The following is a description of a gene set: from publication Tien MT, Girardin SE, Regnault B, Le Bourhis L, Dillies MA, Coppée JY, Bourdet-Sicard R, Sansonetti PJ, Pédron T (PMID 16394013) species: Homo sapiens Human Gene Set: TIEN_INTESTINE_PROBIOTICS_6HR_UP Genes up-regulated in Caco-2 cells (intestinal epithelium) after coculture with the probiotic bacteria L. casei for 6h. Shigella invades the human intestinal mucosa, thus causing bacillary dysentery, an acute recto-colitis responsible for lethal complications, mostly in infants and toddlers. Conversely, commensal bacteria live in a mutualistic relationship with the intestinal mucosa that is characterized by homeostatic control of innate responses, thereby contributing to tolerance to the flora. Cross-talk established between commensals and the intestinal epithelium mediate this active process, the mechanisms of which remain largely uncharacterized. Probiotics such as Lactobacillus casei belong to a subclass of these commensals that modulate mucosal innate responses and possibly display anti-inflammatory properties. We analyzed whether L. casei could attenuate the pro-inflammatory signaling induced by Shigella flexneri after invasion of the epithelial lining. Cultured epithelial cells were infected with L. casei, followed by a challenge with S. flexneri. Using macroarray DNA chips, we observed that L. casei down-regulated the transcription of a number of genes encoding pro-inflammatory effectors such as cytokines and chemokines and adherence molecules induced by invasive S. flexneri. This resulted in an anti-inflammatory effect that appeared mediated by the inhibition of the NF-kappaB pathway, particularly through stabilization of I-kappaBalpha. In a time-course experiment using GeneChip hybridization analysis, the expression of many genes involved in ubiquitination and proteasome processes were modulated during L. casei treatment. Thus, L. casei has developed a sophisticated means to maintain intestinal homeostasis through a process that involves manipulation of the ubiquitin/proteasome pathway upstream of I-kappaBalpha., and this is the list of marker genes: RPL23, HSPA1A, RPL23A, HMGB1, FAM120A, B2M (beta-2-microglobulin), RPS11, ACTB, TPT1, PPIA, EEF1A1, RPS23, RAB2A, RPL4, RPL9P7, RPS2, KLF5, RPLP0, SEL1L3, GAPDH, RPL13, HMGB1P4, MMP24OS, CDC5L, RPS7, RPL39, MYC, RPS19, RPS24, RPS14, RPS27, RPS6, RPL5, EIF5A, EEF1G, NAP1L1, HSPA8, RPS3A, SORL1, FTL, RPL27A, UGT1A10, H3-3A, CRCP, PRNP, ALDH3B1, RPL41, RPL37A, PGK1, UBC, ADCY3, PTP4A2, RPS17